Given this list of marker genes Shh, Tbx5, Hoxa13, Lrp6, Lnpk, Wnt9a, Hoxa11, Crabp2, Ctnnb1, Reck, Rpgrip1l, Twist1, Trp63, Alx3, Mecom, Osr2, Nipbl, Alx4, Wnt3, Hoxd11, Hoxd9, Shox2, Rdh10, Msx1, Runx2, Cacna1c, Aldh1a2, Tfap2a, Tbx3, Wnt7a, Rspo2, Msx2, Hoxa9, Ift122, En1, Osr1, here is a description of the gene set: species: Mus musculus The process, occurring in the embryo, by which the anatomical structures of the forelimb are generated and organized. The forelimbs are the front limbs of an animal, e.g. the arms of a human. Mouse Gene Set: GOBP_EMBRYONIC_FORELIMB_MORPHOGENESIS